Given this list of marker genes LATS2, CDKN2A, CDK5RAP1, APC, INCA1, LATS1, MEN1, TFAP4, CDKN1B, here is a description of the gene set: Human Gene Set: GOBP_NEGATIVE_REGULATION_OF_CYCLIN_DEPENDENT_PROTEIN_SERINE_THREONINE_KINASE_ACTIVITY species: Homo sapiens Any process that stops, prevents, or reduces the frequency, rate or extent of cyclin-dependent protein serine/threonine kinase activity.